The following is a description of a gene set: Mouse Gene Set: GOCC_POSTSYNAPTIC_DENSITY_MEMBRANE The membrane component of the postsynaptic density. This is the region of the postsynaptic membrane in which the population of neurotransmitter receptors involved in synaptic transmission are concentrated. species: Mus musculus, and this is the list of marker genes: Lrfn1, Lrfn2, Afdn, Grid2, Nlgn4l, Epha7 (NCBI Gene Id 13841), Lrrc7, Olfm1, Ryk, Plppr4, Cacng2, Lrrtm3, Tmem240, Neto2, Dlg2, Adra2c, Lzts1, Drd5, Grik5, Grin3a, Efnb2, Slc16a3, Dcc, Cacng3, Iqsec2 (IQ motif and Sec7 domain 2), Lrfn5, Shisa9, Asic2, Cacna1c, Anp32e, Ptprs, Gsg1l, Nptn, Cacng4, Nrcam, Epha4, Igsf21, Lrp8, Adam22, Grin1, Akap9, Drd3, Abhd17c, Chrm3, Shisa6, Igsf11, Lin7c, Lrrtm2, Prr7, Lrrc4b, Prrt1, Clstn2, Sema4c, Rnf10, Lrfn3, Grm5 (glutamate receptor, metabotropic 5), Grin2c, Grik2, Gria3, Nectin3, Sema4f, Tmem108, Ptprz1, Ptprt, Elfn1, Gria4, Grin2a, Actn2, Notch1, Abhd17a (abhydrolase domain containing 17A), Grin2d, Sigmar1, Sema4b, Trappc4, Neo1, Oprd1, Vdac1, Adcy1, Pacsin1, Lin7b, Ptprf, Kcnab2, Atp2b2, Fgf22, Rgs7bp, Slitrk3, Grm1, Gria2, Dgkb, Clstn1, Grik4, Itga8, Rgs9, Dlg3, Robo2, Celsr3, Dagla, Dlg4, Csmd2, Cnksr2, Abhd17b, Erbb4, Mpp2, Grin2b, Neto1, Kcnk2, Grik1, Dgki, Olfm2, Elfn2, Asic1, Adra2a, Nsg2, Grid1, Ptpro, Chrm1, Cacng5 (NCBI Gene Id 140723), Cacng8, Il1rapl1, Lrp1, Grin3b, Shisa7, Scn8a, Scrib, Grik3, Hspb1, Chrm4, Arc, Vangl2, Slc30a1, Nrg1, Lin7a, Lrfn4, Lrrtm4, Prrt2, Adgrb3, Gria1, Cacng7, Slitrk1, Rtn4, Lrrc4, Sorcs2, Tiam1, Slc16a7, Crhr1, Efnb3, Igsf9, Kcnt1, Syndig1, Clstn3, Slitrk5, Stx1a, Kcnh1, Gpr158, Cnih2, Dlg1, Sorcs3, Lrrc4c